The following is a description of a gene set: part of: Developmental Biology electronically inferred by orthology from the curated human pathway This event has been computationally inferred from an event that has been demonstrated in another species.<p>The inference is based on the homology mapping from PANTHER. Briefly, reactions for which all involved PhysicalEntities (in input, output and catalyst) have a mapped orthologue/paralogue (for complexes at least 75% of components must have a mapping) are inferred to the other species. Reactome Pathway: MITF-M-regulated melanocyte development species: Mus musculus, and this is the list of marker genes: Sin3a, Aimp2, Myrip, Sox10 (SRY (sex determining region Y)-box 10), Kitl, Tcf7, Ctnnb1, Tcf7l2 (transcription factor 7 like 2, T cell specific, HMG box), Qars1, Hint1, Kars1, Tcf7l1, Eef1e1, Sirt1, Sumo1, Wnt3a, Mitf, Kit, Tnfsf11, Mapk14, Xpo1, Sytl2, Mapk3, Ep300